The following is a description of a gene set: from publication Chen Y, Wang X (PMID 31504780) Human Gene Set: MIR875_5P studied in species Homo sapiens Genes predicted to be targets of miRBase v22 microRNA hsa-miR-875-5p in miRDB v6.0 with MirTarget v4 prediction scores > 80 (high confidence targets)., and this is the list of marker genes: STAG2, MTRF1L, GPALPP1, STON2 (stonin 2), CREB5, TATDN3, EGFR, FOXF1, SLC2A11, ZFHX3, CSGALNACT2, PGR, FKBP5, SMC5, GPCPD1, ESYT2, TOB2, CEP120, GNA13, RNF139, ITPRID2, MYLIP, FMO2, PRKCE, ZNF587B, SYNE1, TLL2, ZNF333, ARPC5, RAB11FIP2, CARF, SH3D19, CASD1, TMX1, RPE65, DNAJC24 (NCBI Gene Id 120526), RFC1, TRAF3IP3, VKORC1L1, METTL4, EFCAB13, CNTLN, YME1L1, GCA, REEP3, RAB9B, RBM7, GLS, EYA1, FNDC3B, SNX18, RNF180